The following is a description of a gene set: Any process that increases the frequency, rate or extent of a pyroptotic inflammatory response. Human Gene Set: GOBP_POSITIVE_REGULATION_OF_PYROPTOTIC_INFLAMMATORY_RESPONSE species: Homo sapiens, and this is the list of marker genes: GBP3, ZDHHC5, GBP2, CASP3, GBP5, GBP1, ZDHHC9